The following is a description of a gene set: Genes in the cancer module 205. studied in species Homo sapiens Human Gene Set: MODULE_205, and this is the list of marker genes: CLEC3A, GLIPR2, KATNIP, SLC47A1, ACTR5, FBXO32, PTPN14, CRYBA4, ATP5MK (NCBI Gene Id 84833), MDM1, TPX2, NEK2, KISS1, STXBP6, SHCBP1, PRLR, VAV3, PCDHA5, XK, FANCM, PDE6D, SPATA2, PPA2, TASP1 (taspase 1), NRXN3, WNT5B, SEMA6C, ZNF93, PSG9, TRAIP, DTL, NDUFAF4, RBM14, MTNAP1 (mitochondrial nucleoid associated protein 1), CYP19A1, PPM1L, OTUD3, DENND5A, DUOX2, DPYSL5, KCNK15, MPP3, CORO6, PYCARD, IFT81, CABP5, DHX15, PCDHB2, SPOCK1, OPN1SW, SYNJ2, PTPN11, CDH13 (cadherin 13), GFOD2, MYO19, LCE1B, ANGPT2, JCAD, TMEM191A, EXTL2, MAP10, CNN1, LGR6, TWSG1, GIN1, TSHR, ZBED4, ATP8A2, WASF2, FAM114A1, NSUN3, PLVAP, ANXA2, PDPR, KRT4, DNAAF10, PSORS1C2, CNR1, IFT52, DLGAP5, B4GALT4, FANCD2, MCF2, DNAH6, CEP41, DCAF16, CIB2, SSX3, CEP68, ADCY4, TANC2, NPHS1, NEBL, SUPT20H, METTL14, PARD6B, TWIST2, RIF1, CYP4B1, DNER, ST14 (ST14 transmembrane serine protease matriptase), ZNF337, KIF1B (NCBI Gene Id 57598), SULF1, KIAA0930, THUMPD3, B9D1, ZNF681, PLXNB3, CASP8AP2, CLOCK, BOD1, WDR11, HAPLN1, TPTE, FBXL6, KLHL20, TCTN1, MSX1, GCC2-AS1, RSPH1, ZNF444 (zinc finger protein 444), PPP1R9B, HJURP, SEPTIN5, TMEM267, CHML, CAMKMT, FCHSD1, CITED4, PCDH8, ZNF83, CEP76, KIF1A, LRRC49, MIEF2, ARID3A, SRGAP3, FBXL2, SLC35A4, CD200R1, ZNF528, FAM217B, DNAJC6, MEAK7, SUV39H2 (NCBI Gene Id 79723), NAPG, PAQR8, HHAT, DKK2, ZNF266, GLS, ZNF43, EXOC6B, RCOR3, ITGA6, PLCXD1, FBP2, GABRA6, SHH, LUC7L3, HSD17B7, COLGALT2, SCAND3, NARF, CHST14, SEMA5B (semaphorin 5B), GNL3LP1, LCOR, OPA1, ULBP2, AHCYL2, CDC25C, SERPINI1, LINC00520, BLOC1S6, RBFOX1, ADAM23, E2F8, PDLIM2, ASPHD2, SLC45A4, ITSN2, NPEPL1, CRMP1, EPHB2, INTS8, TBC1D19, CELF4, HPS3, SEC14L2 (SEC14 like lipid binding 2), HDAC5, ARMC7, MYRIP, BMP4, ISLR2, WDR47, ZNF702P, CDHR2, CCNA2, TF, NIBAN2, ATG4D, ZNF395, CCDC51, APIP, RBM12B-AS1, ZNF117, LYZL6, COG4, ZFP90, KLRB1, ZNF286A, CCDC28A, TTLL4, WDR89, FDXR, CD109, SOCS7, SMYD4, TUBB4A, ATAT1 (NCBI Gene Id 79969), TMEM65, DIXDC1, DZIP1, RRAGD, CC2D2A (NCBI Gene Id 57545), PRSS16 (NCBI Gene Id 10279), EMILIN1, FBN2, CACHD1, SPA17, GPR88, SLC25A21, GNAZ, TMEM185B, KHDC1, CENPU, CHI3L2, HEY1, TIAM2, INPP5F, EREG, PKD1L1, WNT5A, KIF14, LMBRD1, CXCL13, GALNT10, SOX6, FKBP14, FABP7, KCNJ11, CEP15, GTF2A1L, C22orf46P, SEC11C, ICA1, EIF4EBP1, YEATS2, EXOC2, CACNA2D2, ZNF350 (zinc finger protein 350), TMPRSS4, MRPL57, MUC16, TLR10, AGPAT5, FLYWCH2, GREB1, SNTG2, SAYSD1, CACNB1, PPFIA3, CNTN2, TRAF5, DNAJC22, PPM1E, NECTIN1, IRX5, SBNO1, EGLN3, MOBP, MED18, CEP83, ZNF14, ABCA2, C14orf132, DKK1, GPD2, GPSM2, KIRREL3, CABS1, CENPQ, ADCY10, CACNG4 (NCBI Gene Id 84745), LDAF1, KIFC1, ATP23, SLC26A2, TMEM45B, TP53, DEPDC1B, CCDC121, BCORL1